The following is a description of a gene set: species: Homo sapiens A reduced ability to synthesize postvaccination antibodies against polysaccharides in vaccines, as measured by antibody titer determination following vaccination. Decreased specific antibody response to polysaccharide vaccine Human Gene Set: HP_DECREASED_SPECIFIC_ANTIBODY_RESPONSE_TO_POLYSACCHARIDE_VACCINE, and this is the list of marker genes: IRAK4, CARD11, SASH3, RNF31, TNFRSF13B, TNFRSF13C, CD19, IKBKG, HYOU1, B2M, CORO1A, CR2, ICOS, CASP8, SEC61A1